Given this list of marker genes Il12rb1, Plcb1, Il12b, Tyk2, Il12a, Il12rb2, Stat4, Jak2, here is a description of the gene set: The series of molecular signals initiated by interleukin-12 binding to its receptor on the surface of a target cell, and ending with the regulation of a downstream cellular process, e.g. transcription. Mouse Gene Set: GOBP_INTERLEUKIN_12_MEDIATED_SIGNALING_PATHWAY species: Mus musculus